Given this list of marker genes HLA-DQB1, PI4K2A, FXN, FTL, HTRA2, CTSH, SPTAN1, MOG, NEFL, PODXL, AIP (aryl hydrocarbon receptor interacting protein), HCRT, PTPA, GPR101, ZNF365, TNFSF4, VPS13C, P2RY11, PINK1, SYNJ1, MFN2, ATXN7, CHCHD2, DNAJC6, UCHL1, CNBP, PARK7, SNCA, HLA-DRB1, LRRK2, PRKN, here is a description of the gene set: studied in species Homo sapiens A state of motor restlessness, usually in the lower extremities, that is often but not always accompanied by a subjective sense of inner restlessness, an urge to move, and anxiety or dysphoria. Akathisia Human Gene Set: HP_AKATHISIA